Given this list of marker genes Crh (corticotropin releasing hormone), Ucn, Ucn2, Gnao1, Ucn3, Gnas, here is a description of the gene set: Mouse Gene Set: GOMF_CORTICOTROPIN_RELEASING_HORMONE_RECEPTOR_BINDING studied in species Mus musculus Binding to a receptor for corticotropin-releasing hormone (CRH), a polypeptide hormone involved in the stress response. It is released by the hypothalamus and stimulates the release of corticotropin by the anterior pituitary gland.